Given this list of marker genes Slc28a3, Slc28a2b, Slc28a1, Slc29a1, Slc29a4, Slc25a26, Slc28a2, Adora1, Slc29a2, Slc29a3, here is a description of the gene set: Mouse Gene Set: GOBP_NUCLEOSIDE_TRANSPORT species: Mus musculus The directed movement of a nucleoside, a nucleobase linked to either beta-D-ribofuranose (ribonucleoside) or 2-deoxy-beta-D-ribofuranose, (a deoxyribonucleotide), into, out of or within a cell, or between cells, by means of some agent such as a transporter or pore.